Given this list of marker genes CREB1, GGCX, BGLAP, GPRC6A, DKKL1, PRKG1, WNT4, AKR1C3, here is a description of the gene set: studied in species Homo sapiens Human Gene Set: GOBP_REGULATION_OF_TESTOSTERONE_BIOSYNTHETIC_PROCESS Any process that modulates the frequency, rate or extent of testosterone biosynthetic process.